Given this list of marker genes FBXO21, EVI2B, ASB7, THAP11 (NCBI Gene Id 96844), ST8SIA4, CTCF, CCM2, CSK, FRAT1, JKAMP, FAM89B, CTDSP1, YY1, GAPT, ATXN7L3, ZNF710, OSBPL11, RALA, UBXN6, SF3B2, USP19, ELOVL1, KLF13, ZBTB44, YWHAB, CDC34, BUD13, DCAF7, RNF220, DPP8, CTNND1, MKRN1, NCOA6, CXCL16 (NCBI Gene Id 58191), GLTP, CAPRIN1, LRRC25, TAF5, KDM2A, RHOG, NUP214, MAP3K14, CTDSP2, STX6, SPG21, DDX17, GNB2, CHD8, DUSP7, PHC2, PINK1, ZDHHC7, GDI2, CNPPD1, WBP1L, ZFP36L2, STAU1, GIT2, PIP5K1C, SH2D3C, TMEM250, UBAC1, LILRB1, TNFAIP8L1, PSMG2, VIRMA, ARHGAP1, SRSF9, GABARAP, PRR13, SETD1B, NT5DC2, RNF44, CSF1R, ZNF436, ZNF227, PLIN3, USP3, TLR1, PEX11B, RAB11FIP4, RGS19, IL10RA, ZNF615, CASP8, MARF1, GAPVD1, MARCKSL1, POLR2B, CRTC3, APOBR, GNA12, LRP10 (LDL receptor related protein 10), BMF, PHAF1, RAB8A, NFE2L1, HHEX, ENC1, ENG, POLR2E, CXCR4, SPOP, VPS35, MAPK14, NCKAP1L, ARPC1B, NELFB (negative elongation factor complex member B), NAGS, AP1M1, GIMAP8, THEMIS2, PIK3CD, CBL, PPP1CA, CHCHD4, CMTM3, TRIM8, RNF38, TWF2, KIAA2013, FUCA1 (NCBI Gene Id 2517), ARRDC2, CFP, PLXNB2, VRK3, ILK, TRIM38, ORAI2, RETREG3, SASH3, FOXK1, TGFBR2, ARL6IP5, ZC3H7A, RPS6KA1, PLEKHO2, ZNF282, FHOD1, MADD, MYO1F, SMAD3, CSTF2, PRELID1, AP2M1, PHF23, CHAMP1, RTCB, PRP4K, WIPI2, NELFA, SMARCAL1, CCR2, CTBP1, DAGLB, FRAT2, WDR82 (WD repeat domain 82), PTTG1IP, CNOT8, TOR1A, NLRC4, MNT, ARID1A, SREK1IP1, KDM4A, REST, KMT2A, ARHGAP30, MLXIP, NAP1L4, TACC1, KIF3B, ANKRD13A, NPEPPS, BRD8, GLE1, CALHM2, MRTFA, DDX23, ATF5, POLDIP3, MAP7D1, PAFAH1B2, APMAP, DCAF12, KDM3B, HECA, MAST3, CORO1A, STK24, ARRB2, PIGM (phosphatidylinositol glycan anchor biosynthesis class M), USP22, AP5M1, CYTIP, PURA, ZNF148, here is a description of the gene set: TREM-1 is an orphan immunoreceptor expressed on monocytes, macrophages, and neutrophils. TREM-1 associates with and signals via the adapter protein DAP12/TYROBP, which contains an immunoreceptor tyrosine-based activation motif (ITAM). TREM-1 activation by receptor cross-linking is pro-inflammatory, and can amplify cellular responses to Toll-like receptor (TLR) ligands such as bacterial lipopolysaccharide (LPS). To investigate the cellular consequences of TREM-1 activation, we have characterized global gene expression changes in human monocytes in response to TREM-1 cross-linking in comparison to and combined with LPS. Both TREM-1 activation and LPS up-regulate chemokines, cytokines, matrix metalloproteases, and PTGS/COX2, consistent with a core inflammatory response. However, other immunomodulatory factors are selectively induced, including SPP1 and CSF1 (i.e., M-CSF) by TREM-1 activation and IL-23 and CSF3 (i.e., G-CSF) by LPS. Additionally, cross-talk between TREM-1 activation and LPS occurs on multiple levels. While synergy in GM-CSF protein production is reflected in commensurate mRNA abundance, comparable synergy in IL-1b protein production is not. TREM-1 activation also attenuates the induction of some LPS target genes, including those that encode IL-12 cytokine family subunits. Whereas positive TREM-1 outputs are abolished by the PI3K inhibitor wortmannin, this attenuation is largely PI3K-independent. These experiments provide a detailed analysis of the cellular consequences of TREM-1 activation, and highlight some of the complexity in signal integration between ITAM- and TLR-mediated signaling. studied in species Homo sapiens Human Gene Set: GSE9988_ANTI_TREM1_AND_LPS_VS_CTRL_TREATED_MONOCYTES_DN Genes down-regulated in comparison of monocytes treated with anti-TREM1 and 5000 ng/ml LPS (TLR4 agonist) versus monocytes treated with control IgG. from publication Dower K, Ellis DK, Saraf K, Jelinsky SA, Lin LL (PMID 18292579)